Given this list of marker genes HMGB1, ADIPOQ, SYT11, PIP4P2, TGFB1, CD47, PLSCR1, ATG5, APPL1, CD300LF, ATG3, CD300A, CSK, CNN2, SNX3, RACK1, PRTN3, FCGR2B, SIRPA, MIR181B1, TLR2, DYSF, here is a description of the gene set: species: Homo sapiens Any process that stops, prevents, or reduces the frequency, rate or extent of phagocytosis. Human Gene Set: GOBP_NEGATIVE_REGULATION_OF_PHAGOCYTOSIS